Given this list of marker genes Slc9a6, Slc9a1, Slc9a5, here is a description of the gene set: This event has been computationally inferred from an event that has been demonstrated in another species.<p>The inference is based on the homology mapping from PANTHER. Briefly, reactions for which all involved PhysicalEntities (in input, output and catalyst) have a mapped orthologue/paralogue (for complexes at least 75% of components must have a mapping) are inferred to the other species. studied in species Mus musculus electronically inferred by orthology from the curated human pathway Reactome Pathway: Sodium/Proton exchangers part of: Metal ion SLC transporters